Given this list of marker genes CFTR, SLC4A2, ODAPH, ENAM, AMTN, here is a description of the gene set: Any process that activates or increases the frequency, rate or extent of enamel mineralization, the deposition of calcium salts in tooth enamel. studied in species Homo sapiens Human Gene Set: GOBP_POSITIVE_REGULATION_OF_ENAMEL_MINERALIZATION